The following is a description of a gene set: Mouse Gene Set: GOBP_NEGATIVE_REGULATION_OF_HYDROGEN_PEROXIDE_METABOLIC_PROCESS species: Mus musculus Any process that decreases the frequency, rate or extent of the chemical reactions and pathways involving hydrogen peroxide., and this is the list of marker genes: Stat3, Ptger4, Mpv17l, Mt3, Ctns, Fyn